The following is a description of a gene set: Genes down-regulated in activated versus induced T reg cells. Induced and activated regulatory CD4+ Foxp3+ cells compared from publication Kuczma M, Lee JR, Kraj P (PMID 21642545) species: Homo sapiens Human Gene Set: GSE28130_ACTIVATED_VS_INDUCEED_TREG_DN, and this is the list of marker genes: GPC1, LINC00588, AGT, IRF7, LINC01565, ASTN2, COQ7, SMPDL3B, NPHP4, NRTN, HOPX, NTRK2, CADM3-AS1, CCND1, LHX2, BRSK2, PTGS1, APOB, PDE4C, CCNO, ALDH1B1, COX6A2, ADORA2A, KALRN, DENND2B, RAP1GAP, KLK11, DACH1, UPK1B, ACACA, POP7, WDR13, CNTN1 (contactin 1), GPR37L1, DMTN (NCBI Gene Id 2039), TNFRSF1B, LGALS4, E2F1, NDUFB7, CCL1, SMPD2, SLC35B1, GRIK5, OS9, IFI30, GP2, TEC, TSPO, PLS1, GPR182, TSHB, ALDH3B1, FMO6P, DUSP5, RFPL3S, RUNX2, ARMCX2, HAO1, KLK2, AP3B2, SEMA6C, PVR, HTR2C, STC1, HGF, GPNMB, LAMA3, CRX, HS2ST1, ENTREP3, CDK2, GJB1, ZBTB5, ATP6V1G2, IFNA8, APPBP2, DCC, HYAL3, IL13RA1, DMBT1, NPY6R, TLX2, ERBB2, TNNT1, IGHV3OR16-13, CRLF3, VPS41, SPEF1, CXCL3, GPR31, RREB1, DKK4, NDUFA6, PXN, PNPLA4, OR2F1, DCK, WNT8B, CXCL9, LOXL1 (lysyl oxidase like 1), CDT1, GTF2H2, CALCR, ATP2C2, UNC13A, STMN2, ABCB8, PLK4, KLRA1P, RNF8, B3GAT2, GSS, C2CD2, IGF2, INPP5A, BPHL, LEFTY2, LCN1, SLC5A2, TFF2, SEL1L3, C14orf132 (chromosome 14 open reading frame 132), RPUSD2, CEP43, TMEFF1, KCNH1, NISCH, SLC5A4, NTS, TMPRSS2, FCGR2B, PER1, PTPRU (protein tyrosine phosphatase receptor type U), PPP1R3C, IVD, ARFGEF2, FAM50B, PCCB, ABI1, CACNA1D, HMOX1, HOXB2, PRKAB2, FOXM1, GSTA4, R3HDM1, DMXL2, MVK, ARSL, EPB41L1, ANK1, DNAJB12, DFFB, DDX6, LIG1, MUC1, GNRH1, FUT6, SDS, ARHGEF2, KCND2, HADH, TNNC1, TNFSF9, H3C4, IRF6 (NCBI Gene Id 7452), BARD1, CPB2, TGIF1, CCR9, GNA12, CEACAM5, MMP12, MN1, MFAP5, EHMT2, AMELX, CXCL2, ABCB9, TCEA2, CAMK2B, RFPL1, ICOS, ARHGEF17, REM1, DDIT4, RNASEH2B, IL6R, DAPK2, STX11, HOXB7, TLX1 (NCBI Gene Id 3195), P2RX5, ALDH1L1, XRCC4, ZNF20